Given this list of marker genes JUNB, SOCS3, CTNNB1, SH2B3, TACC1, PTP4A1, TRIM7, LRRC31, TMOD1, SMNDC1, ZNF326, MAFK, RIPK2, DNAJB9, TTC29 (NCBI Gene Id 83894), REL, EGR2, C20orf203, KLHL15, FTH1P5, NPHP3-AS1, CDH23, TUBB1, STX11, SAP130, JARID2, ZMIZ1, FTH1, GNA13, PI3, RAB1A, PPM1D, TP53INP2, NGRN, RAVER2, CD83, MNT, CHMP1B, ZFAND5, HEATR4, FOSB, SLC9A7, PTGER4, PTGS2, WARS1, SAMSN1, SIAH1, TM2D3, MAML1, N4BP3, PITX1, F13A1, CD69, TYR, NR2E3, B3GNT5, IFIT2, MIR23AHG, NR2F1-AS1, ARL8B, ABHD13, RASGEF1B, THRSP, CDKN1A, PLK2, ITPRIP, GZF1, FAM53C, ECT2, CXCR4, PLPPR1 (NCBI Gene Id 54886), USP3, SLC16A6, SERPING1, NR4A3, HCAR3, CCZ1, DCX, ETF1, HBB, LINC01300, BCL3, G0S2, WAC, RAB8B, FSD1L, CXCL2, UTRN, INSIG1, SUGT1P1, YTHDF3, BACH1, OSM, KAT7, TMEM98, CHORDC1, RNF138, KRTAP9-2, YPEL5, DCP1A, MEX3C, METRNL, ATP11A-AS1, NFIL3, NTRK2, HBEGF, ZNF416, DUSP2, CLEC2B, BAG5, SAT1, ZNF703, GPR146, PWWP2B, ZNF282, SLC2A3, ARL4A, KCTD5, GPR88, RAB18, EGR3 (NCBI Gene Id 1960), CYTIP, CPNE4, KBTBD2, L3MBTL3, FOS, MED21, OR51B2, BTG2, OTUD1, NXPE1, RBM15, GPR183 (G protein-coupled receptor 183), MARK1, TPM3, TIPARP, ARL5B, AREG, ZNF667, DUSP1, CRY1, PHACTR1, FETUB, TSC22D2, UBE2D3, SERPINB2, TRAF6, NR4A1, ETV3, TIGAR, CDADC1, RBM7, PTBP2, SPATA6, FEZ1, ATF3, CNTNAP3B, RHOB, RAB11FIP4, PFKFB3, C5AR1, HUS1B, DHX58, CXCL8 (C-X-C motif chemokine ligand 8), CACUL1, ELF4, CCDC198, LIF, CXCL10, ZNF644, FOSL2, MAGEC2, NFE2L2, MTMR6, RGS1, SGK1, RGS2, FZR1, PDE12, NMRAL2P, STPG3-AS1, MCM9 (minichromosome maintenance 9 homologous recombination repair factor), DCTN4, ARL8A, GUCY2C, COL5A2, CSRNP1, CUL3, MIR3142HG, NAMPT, OBP2B, COQ10B, CCL20, HIF1A, SIK1, USP25, here is a description of the gene set: Systems vaccinology has emerged as an interdisciplinary field that combines systems wide measurements and network and predictive modeling applied to vaccinology. Here we used the systems vaccinology approach to study the molecular mechanisms underlying th Human Gene Set: GSE29617_CTRL_VS_DAY7_TIV_FLU_VACCINE_PBMC_2008_UP studied in species Homo sapiens Genes up-regulated in comparison of peripheral blood mononuclear cells (PBMC) from TIV influenza vaccinee pre-vaccination versus those at day 7 post-vaccination. from publication Nakaya HI, Wrammert J, Lee EK, Racioppi L, Marie-Kunze S, Haining WN, Means AR, Kasturi SP, Khan N, Li GM, McCausland M, Kanchan V, Kokko KE, Li S, Elbein R, Mehta AK, Aderem A, Subbarao K, Ahmed R, Pulendran B (PMID 21743478)